The following is a description of a gene set: from publication Chen Y, Wang X (PMID 31504780) species: Homo sapiens Human Gene Set: MIR6769A_5P Genes predicted to be targets of miRBase v22 microRNA hsa-miR-6769a-5p in miRDB v6.0 with MirTarget v4 prediction scores > 80 (high confidence targets)., and this is the list of marker genes: CDHR1, ATP11A, IGF1, CLTRN, RAPGEF2, KCNA3, ZNF275, PTPRN, SYNGAP1, YWHAH, AP1M1, VWA8, RBM38, SCN1B (sodium voltage-gated channel beta subunit 1), RUSC1, MAPRE2, GRIN3A, CLEC12B, BCAN, GLE1, TGM2, TSNARE1, ZBTB4, LIG3, CACUL1, COL4A5 (NCBI Gene Id 1287), HAPSTR1, POLR3H, RNASE13, CCDC146, CACNA2D2, CNTFR, B4GALT5 (beta-1,4-galactosyltransferase 5), CACNA1A, MIF4GD, RSPO4, ROGDI, SLC6A8, RIPK2, B9D1, STMN2, ATP1B2, CACNA1E, MAGI3, INO80D, SRR, ABI3BP, GRIA4